The following is a description of a gene set: Neutrophils play critical roles in modulating the immune response. However, neutrophils have a short circulating half life, are readily stimulated in vitro, and have low levels of cellular mRNA when compared to other blood leukocyte populations. All of these factors have made it difficult to evaluate neutrophils from clinical populations for molecular and functional studies. Here we present a robust methodology for rapidly isolating neutrophils directly from whole blood and develop ‘on- chip’ processing for mRNA and protein isolation for genomics and proteomics. We validate this device with an ex vivo stimulation experiment and demonstrate the ability of the device to discriminate subtle differences in the genomic and proteomic response of peripheral blood neutrophils to direct and indirect stimulation. Lastly, we implement this tool as part of a near patient blood processing system within a multi-center clinical study of the immune response to severe trauma and burn injury and demonstrate that this technique is easy to use by nurses and technical staff yielding excellent quality and sufficient quantity of mRNA for sensitive genomic readout of the host response to injury from publication Kotz KT, Xiao W, Miller-Graziano C, Qian WJ, Russom A, Warner EA, Moldawer LL, De A, Bankey PE, Petritis BO, Camp DG 2nd, Rosenbach AE, Goverman J, Fagan SP, Brownstein BH, Irimia D, Xu W, Wilhelmy J, Mindrinos MN, Smith RD, Davis RW, Tompkins RG, Toner M, Inflammation and the Host Response to Injury Collaborative Research Program (PMID 20802500) Human Gene Set: GSE22103_UNSTIM_VS_GMCSF_AND_IFNG_STIM_NEUTROPHIL_DN Genes down-regulated in neutrophils: untreated versus stimulated by CSF2 and IFNG. species: Homo sapiens, and this is the list of marker genes: HLA-DMA, NUDT14, C12orf57, STC2, MAP4K1, PLEKHG4, MEIS2, AGRP, GPI, UQCRQ, AKAP12, LHPP (NCBI Gene Id 64077), FOS, NANS, TMEM119, LRWD1, PLSCR4, B9D1, GATB (glutamyl-tRNA amidotransferase subunit B), CREB3L1, DOK2, PRMT7, TTK, RPL36, DIPK1B, RAD54L, KLHL17 (kelch like family member 17), CCDC88B, ENOPH1, INPP5B, EGR3, PHGDH, CMBL, FANCA, NDUFB10, CCDC106, ELOVL6, MRPL52 (mitochondrial ribosomal protein L52), PPM1J, SIRT3, PTTG1, ESCO2, PSMB10, HNRNPD, NEXN (nexilin F-actin binding protein), TMEM160, CKAP2L, WDR83OS, FAM98C (NCBI Gene Id 147965), KIZ, COX10, TYROBP, BCAT1, UBE2C, DCPS, TEX9, KLK8, CHD1L, PRELID1, BANK1, CEP41, PFDN6, ACAT2 (acetyl-CoA acetyltransferase 2), TNFSF8, EHD4, FAU, MICOS10, IGHM, SPATA3, NAGA, CLSPN, PYCR2, SKIDA1, MCM5, UNG, THOP1, NENF (NCBI Gene Id 29937), GUCA1A, RNGTT, TIMM13, RTN4RL1, TMEM223, RUVBL2, GSDMD, GALE, TPI1, CENPF, IMPA2, CAPRIN2, COPE, DALRD3, SLC44A2, KCNE3, RPL27, RND2, RASGRP2, EHMT2, MCRIP2, ACOT8, CENPE, SON, MSX1, TTC38, MYB, PLD4, RINL, FES, CBY1, XRCC5, ABCD1, ORAI2, AARSD1, PIMREG, ITGAL, RPL35, CRISPLD2, SH3BP1 (SH3 domain binding protein 1), PPARGC1B, HSH2D, CDCA2, SCAND1, STOM, MCM4, CLEC11A, MAN2C1, PAM16 (presequence translocase associated motor 16), PARD6G (par-6 family cell polarity regulator gamma), NRARP, HDDC2, CMTR1, DCTPP1, RPL37A (NCBI Gene Id 6168), RAB31, FGF18, H3C4, MPG, RND1, STK24, ETV5, NDUFS7, TEX47, ALDH3B1, KNTC1, NXF1, FAM168A, OGFRL1, MIPEP, SAPCD2, SLC6A13, AP1S1, NEFH, TTLL9 (NCBI Gene Id 164395), KRTCAP2, GRM5, RAPGEF3, PNKP, CARS2 (cysteinyl-tRNA synthetase 2, mitochondrial), BRCA2 (BRCA2 DNA repair associated), DSCAM, AMZ1, IQGAP2, SMAD6, CBR1, DCAF4, CCNB2, CDKN3, LZTS2, HAUS4, HSPB1, JMJD6, SIGIRR, CDKN1C, SHB, SLC20A1, HOXA2, TCIRG1, PAX3, MTG1, UQCR11, EGLN3, SPPL2B, SPC25, MRPL2, CISD1, PYCARD, KLF7, HES1, DNAJC4, GPSM3, RAB40C, MSH2, MYO1F, OVGP1, DUSP7, TNNC2, MYG1, FBXO33, VAMP5, DNA2, UCP1